Given this list of marker genes DLD, DBT, BCKDHA, BCKDHB, here is a description of the gene set: Reactome Pathway: Loss-of-function mutations in DLD cause MSUD3/DLDD part of: Maple Syrup Urine Disease studied in species Homo sapiens Mutations in the dihydrolipoyl dehydrogenase (DLD) gene are associated with dihydrolipoyl dehydrogenase deficiency (DLDD), an autosomal recessive disorder characterized by lactic acidosis and neurological deterioration. DLDD is sometimes referred to as Maple Syrup Urine Disease 3 due to its effects on BCKDH function, but the phenotype is distinct due to the involvement of DLD in multiple protein complexes.<br>DLD encodes the shared E3 component of the multiprotein mitochondrial enzymes BCKDH (branched-chain amino acid dehydrogenase), KGDH (alpha-ketoglutarate deydrogenase) and PDH (pyruvate dehydrogenase). In consequence mutations in DLD have pleiotropic effects and manifest with a range of clinical outcomes, including increased urinary excretion of alpha-keto acids and accumulation of pyruvate and plasma branched-chain amino acids in plasma. Mutations in DLD often occur as compound heterozygotes complicating the assignment of pathogenic effect. Moreover, the severity of phenotypic effects displayed in vivo does not correlate linearly with the extent of residual DLD enzymatic activity in vitro. <br>